The following is a description of a gene set: from publication Yevshin I, Sharipov R, Kolmykov S, Kondrakhin Y, Kolpakov F (PMID 30445619) Human Gene Set: HDAC8_TARGET_GENES Genes containing one or more binding sites for (HDAC8) in their promoter regions (TSS -1000,+100 bp) as identified by GTRD version 20.06 ChIP-seq harmonization. species: Homo sapiens, and this is the list of marker genes: TBC1D13, PNMT, ZNF511, FAM53A (family with sequence similarity 53 member A), NDUFAB1, POMGNT2, MAZ (MYC associated zinc finger protein), ZNF511-PRAP1 (ZNF511-PRAP1 readthrough), ADGRB3, GAREM2, ANKMY1, RBM33-DT, NETO2, HTR5A, SFT2D2, VPS51, PTTG1IP, MCRS1, NUDT18, AKR1A1, DGCR2, WDR81, KHSRP, LINC00029 (NCBI Gene Id 100144596), MIR7-3, ARF1, OPLAH, SUMO2, VSIG10L, HIPK2, UBE2E3-DT, RBM33, AGO3, ARHGDIA, TBX6, ZBTB8OS, ATF7IP2, SEC14L1, ANO10, CMTM3, MPC1, BMP8B, ZSCAN31, LINC01056, NUMBL, SMPD4BP, ITFG1-AS1, MAP2K7, RHOT2, FBXO30, LINC03016, LIN9, AIMP2, YPEL1, LINC01732, TUBGCP2, DPH6-DT, NAGLU, CCDC137, SLC20A1-DT, PARP12, TBXAS1, LINC01547, ANKRD65, BRME1 (NCBI Gene Id 79173), DNAJC11, ZFYVE1, UBE3C, PIGL, UBE2E3, SYPL1, PCBP1-AS1, GPR176-DT, SMIM15-AS1, JMJD1C, SMG1P3, CDK5RAP2, FOXK2, DPH6, EPM2A-DT, ADGRB3-DT, SYF2, SLC20A1, IBA57-DT, PEMT (NCBI Gene Id 10400), VSIG10L-AS1, BRWD1, IRF2BP2, TRAPPC10, BEST1, TMED1, DHX40, TULP2, HLCS-AS1 (HLCS antisense RNA 1), ASAP3, LSM10, CCDC136, ENSG00000268460, TMEM245, PRPF40B, IL23A, SNX27, PDCD5, SLX9, LINC02983, CCDC106, GTF2IRD1 (NCBI Gene Id 9569), LINC01635, STRIP1, DUSP28, BANCR, TMEM204, TNFRSF1B, MIR1205, ABHD5, PMS2, DNLZ, HNRNPH1, LEPROTL1, PTMA, EBAG9, USP48, ZNF775, MIR7-3HG, FAH, SNHG20, KEAP1, POLE4, MIR4766, LINC00824, ENO1, NDC1, XPOT, IBA57, SLC25A6, ZNF580, SH2D2A, PIGP, DHRS13, MZT2A, LINC02985, QSOX1, BCL7C, RNF220, SLC7A5P2, SEH1L, SYNJ1, CPNE2, TRMT2A, RBBP4, RAB4A, FHL2, UTP11, DNM1, SRCAP, RANBP1, CC2D1A, C19orf38, RIN3, ZNF581, GPR176, REPIN1 (NCBI Gene Id 96712), IGFL2-AS1, RAB4A-AS1, TMEM131L, ECE1 (endothelin converting enzyme 1), ENSG00000261840, MACROH2A1 (macroH2A.1 histone), SQSTM1